The following is a description of a gene set: Human Gene Set: GOCC_PERINUCLEAR_REGION_OF_CYTOPLASM Cytoplasm situated near, or occurring around, the nucleus. species: Homo sapiens, and this is the list of marker genes: STX10, BTK, EPG5, ABCA1, GALNT6, APEX1, PDCD6, LIMK2, UNC45A, ITGA2, ANP32CP, CLN5, APOD, EIF4A2, PTK2, CABP7, SPIRE1, ZPR1, S100B, AANAT, NUPR1, HSP90AB1, MRFAP1, CALN1, GPER1, NOS2, ANKRD13B, PLSCR1, VPS50, NDFIP1 (Nedd4 family interacting protein 1), ENDOG, APBA1, DMTN, LAPTM5, RAC3, OLFM4, ACHE, KCNA3, DCTN3, CHGA, PLEKHF1, EIF3G, LAMP2, PUM2, RAB34, SPAG9, SYT6, GAPDH, CHI3L1, LAMP3, ACTL9, GALNT4, PKP4, GALNT2, NTRK2, IRAG1, MAF1, MGAT1, MYO6, INHBB, ZFYVE1 (zinc finger FYVE-type containing 1), TAOK1, PLN, TAF10, RASGRP3, STX16, PTCH1, GAK, AATK, FSD2, ATP7B, ADAM10, ITM2C, VAMP2, TRPC7, MOGAT2, PRKD1 (NCBI Gene Id 5587), RASIP1, ATN1, SEZ6, COBL, FIGNL1, FLOT2, HECTD3, TPPP3, CISD2, SLC11A2, S100A16, TMEM134, APC2, PLD1, AZIN2 (antizyme inhibitor 2), IGF2R, VTI1A, VPS52, DBI, NICOL1, TMEM192, CDK5R1, CAV2, CCIN, SEPTIN9, CYLC1, MVP, SLC1A3 (NCBI Gene Id 6507), DLG1, CYLD, PAFAH1B1, DOCK6 (dedicator of cytokinesis 6), PPP1R16B, GBP5, DAB2 (NCBI Gene Id 1601), FAM168B, KCNH2, SBF2, PLCG2, GGT2P, NXT2, FZD5, CDK19 (cyclin dependent kinase 19), RASEF (RAS and EF-hand domain containing), SPMIP6, VPS53, PROCR, KCNB1, XKR8, DICER1, CERT1, RAB1B, SH3RF1, CNTRL, MTPN, CAV1, INPP5K, EHD3, PRKACA, ST8SIA2, CLDN19, CLINT1, TMEM184A, UBR5 (ubiquitin protein ligase E3 component n-recognin 5), GOLGA1, SPINK5, LMTK2, PTOV1, CENPF (NCBI Gene Id 51468), LDB3, PRKAR2B, PTK2B, TLR4, CDKN3, TMEM100, CABP1, DNAJB6, RNF41, AMBRA1, AMFR, SEC31A, KLHL7, GNAS, HMOX1, PHEX, CKAP4, EZR, UGT2B28, HMGB2, MTMR9, PTGES2, KCNS2, NPPA, BCAP31, ANGEL1, SIPA1, PDCL3, TH, SNF8, HIF1AN, SLC30A7, MAP1S, CDH1, CBL, EHD1, STOM, PPM1F, MEX3D, ASGR2, HERC5, SLC39A9, CDK2AP1, ATXN2, TF, CEP43, NANOS1, UBQLN1, TWF1, SLIRP, EIF4E, STMN2, CCDC78, MLF1, PRDX6, MAPK8IP1, SET, JCAD, STAT1, TRIM68, CHODL, VAMP8, PRKCA, S100A4 (S100 calcium binding protein A4), OSBP, NDRG2, TRAPPC12, GNB2, AFTPH, RAP1A (NCBI Gene Id 5906), ATP6V0A1, USP20, NHERF1, P2RX4, SLC39A12, EHD4, RAB8B, EPHA5, RAB38, RHPN2, KIF5A, VPS4A, PATJ, CTIF, PKP1, CSNK1D, CCNT2, PTPRR, INHBA, PARK7, ACSL3, SLC9A1, MOB2, SEC23B (NCBI Gene Id 980), AQP2, SYNJ2, TNK2 (NCBI Gene Id 10188), SERINC5, TENM1, NOS1AP, CCNF, APP, RANGAP1, FLNA, BCL10, OSBP2, MIR223, VAMP3, RAB3IP, MOSPD1, RAD51C, KIF20B, APC, ZNF35, PTPN22, RAB29, LRPPRC, OSBPL3, TOLLIP, CDC20, ADGRB1, HTT, KIRREL1, CIB1, AURKA, BUD23, SIRT2, ANXA6, BRI3, MS4A3, LYN, ATP6V0A2, LMNA (lamin A/C), STX7, FLRT1, CIDEB, CEP250, SPRR3, NANOS3, ARF5, SLC34A1, MLPH, MX1, TPD52L1, MSN, EXOC6, TRPC4AP, EXOC8, OPTN, AKAP6 (A-kinase anchoring protein 6), PSMF1, THBS3, LAMC2, SH3GL2, TTBK1, NDFIP2, AKAP4, NHLRC1, ALOX12B, SLC5A1, TNFSF13B, USP29, DEPDC5, DNM3, STX6, ANKRD13D, RELT, MOB4, SEPTIN14, PKN2 (protein kinase N2), UGT1A1, PLAAT3, PRR7, MALT1, CABP2, NELL1, SRCAP, RAP1GAP2, PCLAF, RAB15, SEC23A, ACTN4, CRBN, EHD2, TSC1, FAT1, PAK2, ARHGAP1 (NCBI Gene Id 392), BAG5, STH, ALOX5, LAMP1, UPF1, ATXN10, MCM3, MYO9B, PACSIN1, GDPD5, PLEKHG5, NOX4, EIF2AK3, CDK5RAP2, SRC, FXR1, PDLIM4, KIF1A (NCBI Gene Id 654843), CCR2, CX3CR1, ANXA4, LCE1D, LIMS1, AVPR2, CASC3, MTDH, SLC2A12, STK16, HSF1, PTGDS, FZD9, MYRIP, GGPS1, OAS2, MIR214, RD3, VPS33A, PLEC, SHTN1, PRKN, SELENOM, TLK2, FMR1, MAGEE1, TYR, ERBB2, TAMALIN, SPATA32, CPEB4, TFRC, PINK1, REP15, PPIB, GDPD1, CSF1, SPAST (NCBI Gene Id 6683), SRD5A1, TRAK1, MAD2L1, STXBP1, FOXR1, RBM4, APBA3, OSBPL6, CCAR1, TRMT112, AP1G1, AIFM1, VCP, COPS8, PRKCE, AXIN1, NMRAL1, TPD52, TWF2, RAB4A, DAAM1, STX8, GBP2, FBXL5, DOK1, PLA2G2A, TESK1, MAGI2, IGF2BP1, GSDMA, GDPD3, WWC1, ZNF675, FASLG, DEF6, VPS35, NDOR1, MTMR6, MAP2K2, RANGRF, PDE2A, RAB11FIP4, ZDHHC19, VAMP5, SELE, SLC2A10, SLC39A13, MLC1, IFITM3, MIR19B1, DDX4, CUL7, PIK3R1, NOS1, S100A14, PRKRA, TRAPPC2B, EIF4A1, TGFA, SYNC, TSPAN1, RNF128, TNFSF12, DNAJA1, EGFR, CX3CL1, WDR44, RAB3C, RANBP2, FYN, CALCOCO2, HSP90AB3P, ZFTRAF1, SYNJ1, MYC, APLP1, KIF5B, DDX6, EIF2AK2, LNPEP, SYT5 (NCBI Gene Id 6861), HSP90AA2P, CLU, STK33, COPS3, TSNAX, SEPTIN12, CORO1B, CTNNB1, HHATL, PRKCG, TP53BP2, EIF4H (NCBI Gene Id 94573), STC2, NDRG1, KCNS1, CMYA5, SERPINF1, TAF8, MOBP (myelin associated oligodendrocyte basic protein), DYNC1I1, ARFGEF2, BCL3, LCP1, RAPGEF2, PICALM, NME2, TSTD1, HSP90AB4P, SYP, DNM1L, EXOC3, SYNRG, USP33, SERHL2, PRKCD, NLRC3, RAB10, HSP90AA1, STBD1, SNX5, KRT18, RAD51, GLB1, CTSB, SCN5A, BANK1, MAP2K1, SLC8A3, DISC1, ATP9B, SYT4, LAMB1, ARF3, FBXW8, HSPA1B, ITGA3, SORBS2, CLIC4, SPP1, SNAP47, LGMN, STING1, CCDC42, BUB1B, HSPA1A, MAP7, RACK1, NPC1, SLC2A4, WRNIP1, UNC45B, PRDX5, CYBB, EML1, CYLC2, CYB5R4, CAPN6, S100A13 (NCBI Gene Id 6284), ANKRD13A, OBSL1, OSBPL7, SBF1, SERBP1, GBP3, UPF2, TGM2, AIF1, LPXN, YTHDC2, ENPP3, RAB4B, HEATR5B, CAPN2, ARFGEF1, ADCY10, TRAPPC2, MAP3K4, ZDHHC20, SCEL, MTMR2, NEURL1, NEDD4, EXOC1, MOGAT3, PTPRM, TRIM37, BICD1, MT3, MYO16 (NCBI Gene Id 23026), HIP1R, CTLA4, COPS5, STK26, MYO1B, UBQLN4, TRAF6, SEC16A (NCBI Gene Id 9919), ALDH1A2, HDAC6, TRIP10, NANOS2, CD34, MAP1B, RASD1, HEPH, HRAS, OPN1SW, MAP6, SNCA (synuclein alpha), DAB1, OSBPL1A, HSP90B1, S100A6, CALR, SYAP1, ITPR1, INF2, MAPKAP1, TARBP2, PREX1, VPS54, SNAPIN, PI4KB, PICK1, MAL2, TRARG1 (NCBI Gene Id 286753), CLIC1, NPY, PLVAP, BRSK2, NCS1, NOCT, ABL1, SNAP25, PKN3 (NCBI Gene Id 29941), SLC5A3, FMN2, MIR18A, RHBDD2, ASPSCR1, DGAT2, USP2, BNIP2, PSTPIP1, MMD2, GAD1, SNCG, DNAJB2, M6PR, PER2, CERKL (NCBI Gene Id 394232), TRIM13, CCDC38, AGGF1, OSBPL2, VPS33B, HRNR, HCN4, MAEL (maelstrom spermatogenic transposon silencer), CA4, KLHL20, RARA, FAF1, MAPRE3, ABCD1, ATP9A, SERINC3 (serine incorporator 3), USO1, VTI1B, ARHGAP10, GALNT1, PIK3CA, YWHAB, ECE1, HFE, PLCZ1, WBP2NL, ITGB1BP1 (integrin subunit beta 1 binding protein 1), LRAT, RAB24, ATP7A, PDE4A, HYAL2, GBP4, GALNT3, APLN, ITGB1, XRCC3, SLC17A3 (solute carrier family 17 member 3), EMP2, TSC2, BPTF, RASA2, RAB14, PTGES, KCNA5, ATCAY, TPPP, SRFBP1, TPD52L2, HMGCLL1, STX4, GTPBP4, CDH13, MAPK8IP3 (NCBI Gene Id 89855), CHERP, DCUN1D3, CYBA, RAB3B, TRAF4, EPN3, FKBP4, HSP90AB2P, MTMR14, BDNF (NCBI Gene Id 627), SORT1, ATP2C2, ANKRD13C, SLK, HCRT, CDK7 (NCBI Gene Id 116024), VAPA, RTRAF, CYFIP2, KAT5, RAB40B, RNF207, TSNAXIP1, UBE2I, ATP2A1, YBX3, PDE9A, RAB3A, ANP32A, CYFIP1, DAOA, TRAIP, COPS6, PKHD1, PCSK9, ATRAID, TNKS2, NF2, TRAPPC2L, MEIS2